The following is a description of a gene set: Genes down-regulated in comparison of untreated CD4 T cells versus those treated with TGFB1 and IL6. Human Gene Set: GSE39820_CTRL_VS_TGFBETA1_IL6_CD4_TCELL_DN TGF-beta3 produced by developing Th17 cells induces highly pathogenic T cells that are functionally and molecularly distinct from TGF-beta1-induced Th17 cells. The microarray data represent a distinct molecular signature for pathogenic versus non-pathogenic Th17 cells. species: Homo sapiens from publication Lee Y, Awasthi A, Yosef N, Quintana FJ, Xiao S, Peters A, Wu C, Kleinewietfeld M, Kunder S, Hafler DA, Sobel RA, Regev A, Kuchroo VK (PMID 22961052), and this is the list of marker genes: BBS5, FRMD4B, DUSP16, VIM, EAF2, PAFAH1B1, TMEM205, SGK1, TSPAN6, IL17A, TBC1D14, NFE2L2, STX5, RETREG1, LXN, B4GALT1, NT5E, NICN1, PLEKHG2, SNAPC1, EPB41L2 (NCBI Gene Id 2037), SMOX, AMFR, PTPN1, RTRAF, ARHGAP39, C6orf120, YIF1B, TMEM50A, TGDS, RGS1, CSRNP1, NCBP2AS2, HEXB, PGM2, YPEL5, UNC119B, CSTB (cystatin B), RCAN3 (RCAN family member 3), PC, PHF20, FURIN, DCTN4, PICALM, ATOSB, BIN3, ACSBG1, MROH1, SLC48A1, NR1H2, DNASE1L1, ABI1, YIF1A, CHM, TMUB2, RNF149, PLAC8, N4BP3, STX18, GAB2, EID1, GALNT9, TMEM14C, GRK5, GEM, PRKCZ, SH3RF1, VPS37A, DENND10, SPATA13, SGPL1, RAB28, TNFRSF1A, SERPINB1, TRPM4, PSAP, ALDOA, PPME1, CREB3L2, FLT3LG, CORO7, MT2A, GPSM2, PLD2, IGKC, FEZ2, BNIP5, NECAP2, LTB4R, CAPZA1, FOSL2, RNF130, SERTAD1, ADPRM, GFPT2, ITGA3, PFN2, IL12RB1, PLEKHF2, MCTP2 (NCBI Gene Id 55784), SASH3, PPP1CC, RCBTB1 (RCC1 and BTB domain containing protein 1), ATP6V1D, MFSD1, GJA1, WDR47, TMX4, CCDC63, CNP, TSPAN5, MKNK2, SPART, TAX1BP3, CCNC, HS1BP3, EXOG, ZDHHC18, ZNF496, STX2, ACP5, CYTH4, ARMCX3, SIAH1, DRAM2, XRCC4, VAMP4, ACVR1B, CD38, STX12, ACAP1, RNF181, PLP2, CELA1, FBXO38, FTH1, MADD, SYT11, CDS2, CCDC6, EIF2B2, PSMD8, P4HA1, LONP2, TBC1D19, ETV6, KAT2B, ME2, LIPE, FNDC3A, TNFRSF12A, ZNF655, CHMP5, TRAF6, CCDC88C, CDC14B, PAPSS1, CD86, LIMK2, CRK, ATP6V0E1, TOX2, RBMS2, TMEM60, UGP2, MAP1LC3A, TMEM30A, DAZAP2, ZNRF1, SMPD1, LBH (NCBI Gene Id 81606), GALK1, TACC2, TLE6, MAPK9, GATM, NAB1, REXO4, SMIM3, NINJ1, B9D2, ANXA4, YPEL3, RAB11A, ULK1, CSNK2A2, SLC41A2, CTSC, ABI3, PLSCR3, GKAP1, EDEM3, ENTREP3, CAST, CDR2, AFG3L2 (NCBI Gene Id 573970), ALDH3A2 (aldehyde dehydrogenase 3 family member A2), PLOD2, MGST3, MAPRE1